Given this list of marker genes GLYATL2, CYP4F12, ABCD1, CYP4F2, ACADL, AIG1, ADTRP, CYP4A11, CYP4F3, here is a description of the gene set: species: Homo sapiens The chemical reactions and pathways resulting in the breakdown of a long-chain fatty acid. A long-chain fatty acid has an aliphatic tail containing 13 to 22 carbons. Human Gene Set: GOBP_LONG_CHAIN_FATTY_ACID_CATABOLIC_PROCESS